The following is a description of a gene set: species: Mus musculus Adenylate cyclase inhibitory pathway Mouse Gene Set: REACTOME_ADENYLATE_CYCLASE_INHIBITORY_PATHWAY, and this is the list of marker genes: Adcy5, Adcy3, Adcy2, Adcy8, Adcy6, Gnai3, Gnai1, Gnat3, Adcy4, Adcy7, Adcy9, Adcy1, Gnai2, Gnal